The following is a description of a gene set: from publication Zhan F, Tian E, Bumm K, Smith R, Barlogie B, Shaughnessy J Jr (PMID 12393520) To identify genes linked to normal plasma cell (PC) differentiation and to classify multiple myeloma (MM) with respect to the expression patterns of these genes, we analyzed global mRNA expression in CD19-enriched B cells (BCs) from 7 tonsils, CD138-enriched PCs from 11 tonsils, 31 normal bone marrow samples, and 74 MM bone marrow samples using microarrays interrogating genes. Hierarchical clustering analyses with genes clearly segregated the 4 cell types, and chi-square and Wilcoxin rank sum tests (P <.0005) identified 359 and 500 previously defined and novel genes that distinguish tonsil BCs from tonsil PCs (early differentiation genes), and tonsil PCs from bone marrow PCs (late differentiation genes), respectively. MM as a whole was found to have dramatically variable expression of EDGs and LDGs, and one-way analysis of variance (ANOVA) was used to identify the most variable EDGs (vEDGs) and LDGs (v1LDG and v2LDG). Hierarchical cluster analysis with these genes revealed that previously defined MM gene expression subgroups (MM1-MM4) could be linked to one of the 3 normal cell types. Clustering with 30 vEDGs revealed that 13 of 18 MM4 cases clustered with tonsil BCs (P =.000 05), whereas 14 of 15 MM3 cases clustered with tonsil PCs when using 50 v1LDG (P =.000 008), and 14 of 20 MM2 cases clustered with bone marrow PCs when using 50 v2LDG (P =.000 09). MM1 showed no significant linkage with normal cell types studied. Thus, genes whose expression is linked to distinct transitions in late-stage B-cell differentiation can be used to classify MM. The vEDG up-regulated set: most variable early differentiation genes (EDG) with similar expression patterns in tonsil B lymphocytes (TBC) and multiple myeloma (MM) cells compared to the plasma cells from tonsil (TPC) and bone marrow (BPC). Human Gene Set: ZHAN_VARIABLE_EARLY_DIFFERENTIATION_GENES_UP studied in species Homo sapiens, and this is the list of marker genes: OR1G1, ANXA2 (annexin A2), CTSL, CUL7, PTPRN, GNB3, BCLAF1 (BCL2 associated transcription factor 1), HOXB2, POU5F1, AQP2, FGL2, PIK3R2, WWOX, BCR, CD3E, AEBP1 (NCBI Gene Id 165), WNT10B